The following is a description of a gene set: Immune cell-specific expression is one indication of the importance of a gene's role in the immune response. In order to identify such patterns, we set out to broadly profile gene expression in a variety of immune cells. from publication Abbas AR, Baldwin D, Ma Y, Ouyang W, Gurney A, Martin F, Fong S, van Lookeren Campagne M, Godowski P, Williams PM, Chan AC, Clark HF (PMID 15789058) Genes up-regulated in comparison of unstimulated memory CD4 CD8 T cells versus stimulated CD4 CD8 T cells. Human Gene Set: GSE22886_UNSTIM_VS_STIM_MEMORY_TCELL_UP studied in species Homo sapiens, and this is the list of marker genes: CAPN2, TMEM9B, RGS14, RETREG1, CHI3L2, PI4KB, GPKOW, DYNC2H1, PLEKHB1, PIP4K2A, CTDSP2 (NCBI Gene Id 51589), VWA7, BIN1, DPEP2, NR3C2, SKAP1, IGBP1, FGF9, KDM4C, BEX4, CTDSP1, TBCC, CLEC5A, CNPY3, PTEN, RPLP2, CNN2, VNN1, PPP6R3, EIF3H, S1PR4, PARP16, SLC6A16, HIVEP2, TSC22D1, CNNM1, ZNF688, SIGIRR, GLRX, TMEM123, MUC2, FAU, CA5A (NCBI Gene Id 763), ENSG00000274253, PIGC, KCNIP1, LDLRAP1, MZF1, OSBPL8, ECHDC2, TRBC1, RUNX1, CNOT8, NDRG3, IFNA16, DPYD, TLE4, HMCES, VILL, ATP6V1G1, ZNF337, PRMT2, SESN1, KRBOX4, CSGALNACT1, CUTA, EPHB2, PRKCH, ICAM3, EPHB1, SEPTIN9, JUND, ITGB2, LIPA, CAPG, PPP6R2, IFNAR2, CAT, ITGA4, THAP12, CERK, TMEM80, LINC00623, SNX3, DBP, FBXO9, JUN, MYBL1, GOLGA7, FCMR, HFE, MCF2L, SNX6, IL5RA, CDC25B, HMGN4, XPA, ACAP2, TMC6, MXD4, NAGPA, MEAK7, MPRIP, DNAJB2, DNM3, GGA1, SHC1, CALHM2, ZNF133, ZNF721, TNFSF12, LDAF1, TRAV8-3, TSPAN32, NAIP, SCAMP1, SMARCA2, FAM117A, PLCG1, POU6F1, SSR2, SLC22A18, MAPK10, SPTBN1, PITPNC1, TRAPPC6A, DAZAP2, FBXL5, EHD1, SUN2, TOP2B, RNASE3, PYCARD, PIK3R1, PRR5, CCNI, VNN2, MOAP1, TPD52L1, NHERF1, FLI1, TRDV2, NINJ2, AVPR1B (NCBI Gene Id 553), GMEB2, BNIP3L, EPPK1, STK38, HCN4, RBM22, LGALS4, CCKAR, NMT2, EEF1D, RAP2B, SIRPG, ING4, PRKCZ, ARHGAP5, GPD1L, ALPP, LIME1, KLRG1, DALRD3, ADGRE5, MARCKSL1, PCDHGA1, SIDT1, LSM14A, GPSM3, MARCHF8, ARL2BP, TCF20, VENTX, PTPN4, CITED2, ZGPAT, NKX3-1, INPP5K, CREBL2 (NCBI Gene Id 1389), S100A4, AQP1, TTC9, INPP5D, CD300A (CD300a molecule), UXT, CDK20, RPS9, ANKH, UBA52, AGO4, LCP2 (lymphocyte cytosolic protein 2), NSA2, RAP1GAP2, MYO1F, ITGA6, TPBG, IER2